Given this list of marker genes KIAA0586, ACTB, ZEB2, TCF4, TP63, PORCN, IKBKG, PIGY, PNPLA6, GPC3, CHAMP1, STAG1, TMCO1, MASP1, TFAP2B (transcription factor AP-2 beta), RNF216, WDR19, CDH2, HDAC4, ZMYND11, TFAP2A, PIGV, PIGL, GDF11, ARHGAP31, NONO, PIGO, HS2ST1, MEGF8, ASXL1, UBA2, COLEC11, PGAP2, ASXL3, TNRC6B, GPC4, CSPP1, KRAS, MDH2, CKAP2L, H4C9, PPP2R5D, PGAP3, COLEC10, DHODH, KDM5B, TRRAP, JARID2, PIGW, KDM1A (NCBI Gene Id 23028), DDX6, HNRNPK, here is a description of the gene set: Supernumerary nipple Human Gene Set: HP_SUPERNUMERARY_NIPPLE Presence of more than two nipples. studied in species Homo sapiens